Given this list of marker genes Tox, Spn, Irf4, Mtor, Brd2, Ep300, Opa1, Foxp3, Otud5, Slamf6 (NCBI Gene Id 80894), Tgfb1, Rhoa, Stat3, Il6ra, Loxl3, Batf, Il6, Ctsl, Cd69, Tbx21, Il23a, Kctd9, Lgals1, Stat6, Tnfsf18, Bcl2, Ly9, Brd4, Il4, here is a description of the gene set: Mouse Gene Set: GOBP_ALPHA_BETA_T_CELL_LINEAGE_COMMITMENT The process in which a pro-T cell becomes committed to becoming an alpha-beta T cell. species: Mus musculus